The following is a description of a gene set: Prominent ear helix Human Gene Set: HP_PROMINENT_EAR_HELIX studied in species Homo sapiens Abnormally prominent ear helix., and this is the list of marker genes: ZMPSTE24, PYCR1, LMNA, AFF2, ZMIZ1, ACBD5, DOCK7